Given this list of marker genes AP2A2, AP2A1 (adaptor related protein complex 2 subunit alpha 1), GRIA3, AP2S1, PICK1, GRIA2, PRKCG, PRKCA, GRIA1, PRKCB, AP2M1, GRIP2, NSF, TSPAN7, GRIA4, GRIP1, AP2B1, here is a description of the gene set: Trafficking of GluR2-containing receptors is governed by protein protein interactions that are regulated by phosphorylation events. GluR2 binds NSF and AP2 in the proximal C terminal region and binds PICK and GRIP1/2 in the extreme C terminal region. GluR2 interaction with NSF is necessary to maintain the synaptic levels of GluR2-containing AMPA receptors both at basal levels and under conditions of synaptic activity. GluR2 interaction with GRIP helps anchor AMPA receptors at the synapse. Phosphorylation of GluR2 at S880 disrupts GRIP interaction but allows binding of PICK. PICK is activated by Ca sensitive Protein kinase C (PKC). Under basal conditions, in hippocampal synapse, GluR2-containing AMPA receptors (GluR2/GluR3) constitutively recycle between the synapse and the endosome by endocytosis and exocytosis. GRIP anchors the receptors at the synapse while PICK interaction internalizes the receptors and NSF helps maintain the synaptic receptors. Cerebellar stellate cells mainly contain GluR3 homomers as Ca permeable receptors. The interaction of GluR3 and GRIP is disrupted by PICK interaction by phosphorylation of equivalent of S880 residue in GluR3. Under conditions of repetitive presynaptic activity, there is PICK dependent removal of GluR2-lacking AMPA receptors and selective incorporation of GluR2-containing AMPA receptors at the synapse. The GluR2-containing AMPA receptors are first delivered to the surface by PICK and mobilized to the synapse by NSF dependent mechanism (Liu SJ and Cull-Candy SG Nat Neurosci. 2005 Jun;8(6):768-75) Reactome Pathway: Trafficking of GluR2-containing AMPA receptors species: Homo sapiens part of: Trafficking of AMPA receptors